Given this list of marker genes RP1, SAMD11, RPGRIP1L, RORB, NAGLU, NTRK2, RPGRIP1, SAMD7, NRL, BBS4, here is a description of the gene set: studied in species Homo sapiens Development of a rod cell, one of the sensory cells in the eye that reacts to the presence of light. Rod cells contain the photopigment rhodopsin or porphyropsin and are responsible for vision in dim light. Human Gene Set: GOBP_RETINAL_ROD_CELL_DEVELOPMENT